The following is a description of a gene set: Genes positively differentially expressed in cell type: MigDC (migratory dendritic cell) upon treatment with cytokine: IFN-κ in mouse lymph nodes in vivo. from publication Cui A, Huang T, Li S, Ma A, Pérez JL, Sander C, Keskin DB, Wu CJ, Fraenkel E, Hacohen N (PMID 38057668) studied in species Mus musculus Mouse Gene Set: CUI_MIGDC_IFNK_RESPONSE_UP Cytokines mediate cell-cell communication in the immune system and represent important therapeutic targets. A myriad of studies have highlighted their central role in immune function, yet we lack a global view of the cellular responses of each immune cell type to each cytokine. To address this gap, the authors created the Immune Dictionary, a compendium of single-cell transcriptomic profiles of more than 17 immune cell types in response to each of 86 cytokines (>1,400 cytokine-cell type combinations) in mouse lymph nodes in vivo. A cytokine-centric view of the dictionary revealed that most cytokines induce highly cell-type-specific responses. For example, the inflammatory cytokine interleukin-1β induces distinct gene programmes in almost every cell type. A cell-type-centric view of the dictionary identified more than 66 cytokine-driven cellular polarization states across immune cell types, including previously uncharacterized states such as an interleukin-18-induced polyfunctional natural killer cell state., and this is the list of marker genes: Rnf213, Cacybp, Ifi27l2a, Xaf1, Zbp1, Slfn2, Ifitm3, Trim30a, Ifit3, Plac8, Cd81, Ifit1, Cxcl9, Sp100, Ifi211, Stat1, Trim30d, Cd37, Isg15, Eif2ak2, Slfn5, Irf7